Given this list of marker genes Nop53, Vcp, Tnip1, Zc3h12a (NCBI Gene Id 230738), Tank, here is a description of the gene set: species: Mus musculus Mouse Gene Set: GOBP_POSITIVE_REGULATION_OF_PROTEIN_DEUBIQUITINATION Any process that activates or increases the frequency, rate or extent of protein deubiquitination.